Given this list of marker genes SMC5, MIR222, VAPB, ZBED1, ZC3H12A, VAPA, CCNK, PRKN (parkin RBR E3 ubiquitin protein ligase), APOBEC3H, CCL8, EIF2AK4, SMC6, MIR221, here is a description of the gene set: studied in species Homo sapiens Human Gene Set: GOBP_NEGATIVE_REGULATION_BY_HOST_OF_VIRAL_GENOME_REPLICATION A process in which a host organism stops, prevents or reduces the frequency, rate or extent of viral genome replication.